The following is a description of a gene set: species: Homo sapiens The series of molecular signals initiated by collagen binding to a cell surface receptor, and ending with the regulation of a downstream cellular process, e.g. transcription. Human Gene Set: GOBP_COLLAGEN_ACTIVATED_SIGNALING_PATHWAY, and this is the list of marker genes: COL4A3, COL4A5, DDR2, SYK, COL1A1, UBASH3B, GP6, DDR1, COL4A6, ITGA11, OSCAR, COL4A1, ITGA2 (integrin subunit alpha 2), COL4A2, TSPAN9, JAK2